The following is a description of a gene set: Genes with low-CpG-density promoters (LCP) bearing tri-methylation mark at H3K4 (H3K4me3) in MEF cells (embryonic fibroblasts). Somatic cells can be reprogrammed to a pluripotent state through the ectopic expression of defined transcription factors. Understanding the mechanism and kinetics of this transformation may shed light on the nature of developmental potency and suggest strategies with improved efficiency or safety. Here we report an integrative genomic analysis of reprogramming of mouse fibroblasts and B lymphocytes. Lineage-committed cells show a complex response to the ectopic expression involving induction of genes downstream of individual reprogramming factors. Fully reprogrammed cells show gene expression and epigenetic states that are highly similar to embryonic stem cells. In contrast, stable partially reprogrammed cell lines show reactivation of a distinctive subset of stem-cell-related genes, incomplete repression of lineage-specifying transcription factors, and DNA hypermethylation at pluripotency-related loci. These observations suggest that some cells may become trapped in partially reprogrammed states owing to incomplete repression of transcription factors, and that DNA de-methylation is an inefficient step in the transition to pluripotency. We demonstrate that RNA inhibition of transcription factors can facilitate reprogramming, and that treatment with DNA methyltransferase inhibitors can improve the overall efficiency of the reprogramming process. Mouse Gene Set: MIKKELSEN_MEF_LCP_WITH_H3K4ME3 studied in species Mus musculus from publication Mikkelsen TS, Hanna J, Zhang X, Ku M, Wernig M, Schorderet P, Bernstein BE, Jaenisch R, Lander ES, Meissner A (PMID 18509334), and this is the list of marker genes: Arhgef11, Lum, Masp1, Emp3, Zfp583, Mrps21, Tnfrsf14, Vegfd, Tbxa2r, Xdh, Rnf123, Ecscr (NCBI Gene Id 68545), Lsp1, Fhl1, Cyp2j6, Olfml1, Zfp57, Myo7a, Tef, Gstm2, Sec16b, Slfn2, Cpa6, Cyp4f13, Hacd4, Cab39, Dapk3, Pcolce, Rdh5, Rab7b, Ldb3, Casp4, Ifi35, Tnks1bp1, C1qtnf6, Prickle3, Pinlyp, Arap1 (ArfGAP with RhoGAP domain, ankyrin repeat and PH domain 1), Snx10, Glrx, Prrg2, Glmp (glycosylated lysosomal membrane protein), Trex1, Osgin1, Serpinb8, Lgals9, Ampd3, P2rx6 (purinergic receptor P2X, ligand-gated ion channel, 6), Ccl7, BC028528, Ccn4, Acot11, Emilin1, Gal3st4, Arhgdib, Btc, Serpinb9, Rab43 (NCBI Gene Id 70089), Trim21, Ccdc9, Ggnbp1, Tapbpl, 1700010I14Rik, Lpin3, Il18rap, Lgals3bp, Ddr1, Mrgprf, Zfand6, Fbxw10, Xaf1, Soat2, Sh3kbp1, Scn2b, Tlr4, Wars1, G430095P16Rik, Phyhd1, Dab2ip, Akna, Pspn (NCBI Gene Id 19197), Mab21l3, Akr1c14, Casp12, Capg (NCBI Gene Id 12332), Plppr2, Ikbke, Mmp19, Ccl2, Gpr173, Tmem176a, Sardh, Nnmt, Ecm1, Col3a1, Tmem248, Zscan2, Pdgfrb, Rnase10, Zmym2, Iqsec2, Pkig, Rufy4, Serpinf1, Tns2, Spaca6, Tmem176b, Anxa1, Elovl1, Styxl2, Angptl2, Ccn5, 2900026A02Rik, 6820408C15Rik, Aspn, Nyap1, Il17rc, Ecm2 (NCBI Gene Id 71546), Vwa5a, Inhba, Gpsm3, Ifit1bl2, Ogn, Gbp2, Ifit1, Cp, Hgf, Postn, Dmpk, Il1rn, Mr1, Actg2, Col6a1